Given this list of marker genes KALRN, CLIC1, HSPG2, FHOD3, VAMP8 (vesicle associated membrane protein 8), PLOD2, KDELR3, ARF4, P4HA2, MYH6, TTR, SGCE, PLOD1, TCERG1, TYRO3, ENTREP1, STARD10, MBNL2, RRBP1, PTPRM, AQP8, WARS1, AMFR, SNAI1, SURF4, LMBRD1, VEGFA, UBE2Q2, TFPI, ENPEP, PDIA3, AMOTL2, CYP26A1, PGA5, ZNF644, CCNC, SLC7A1, EFEMP2, MYL3, B4GALNT2, TST, YPEL2, ITGB1, LAMC1, EXT1, APP, MFGE8, SFMBT2, YAF2, CTSZ (NCBI Gene Id 1522), TMED2, GATA6, GLUL, NID2 (NCBI Gene Id 95183), EPAS1, COL4A2, DOCK9, CREB3L1, SPOCK1, FKBP9 (NCBI Gene Id 90212), FUT8, FLRT3, PTH1R, LRPAP1, CLU, CST3 (NCBI Gene Id 1471), GNAS, CITED2, FBXL22, SYCP3, GRINA, GHR, LAMB1, ERP44, COL4A1, GNG10, CDC42SE2 (NCBI Gene Id 56990), ANKRD50, CCND2, HS3ST1, IGFBP4, LPP, MPZL2, BACH1, F3, HOXC6, TLNRD1, ID2, FURIN, SUSD2, GANAB, SEMA6D, TCF7L2, SLC38A1, MSL3, RCOR1, ZYX, ZFHX3 (NCBI Gene Id 463), HSDL1, PXDN, SLC16A1, THBD, JUND, GNA12, CCN1, COL4A5, GNS, MDFIC, SPINK1, P4HA1, GREM2, TIMP3, DDAH1, PSAP, CDC42EP1, CD38, STRA6, NR2F2, PTPN9, P4HB, FNDC3A, RAMP2, TNFRSF10B, EPOP, PARVB, LGMN, PSPH, FDX1, KDELR2, CUL1, SRPRB, RCN1 (NCBI Gene Id 5954), INTS6L, PLAT, EPHB4, ANXA2, SERPING1, LAMA1, GGTA1, ATP1B1, DYRK2, CALU, PDE1B, HERPUD1, SEMA6A (NCBI Gene Id 57556), KIT, CASKIN2, GALNT2, MAN1A2, SPARC, PRPF38B, SRGN, CALM1, CITED1, SOX17, CDH5, NID1, CTSV, ATP6AP1, COBLL1, B2M, FBLN2, RNF24, CRYAB, SERPINH1 (NCBI Gene Id 89588), CYB561A3, NR4A1, here is a description of the gene set: Elongin A is a transcription elongation factor that increases the overall rate of mRNA chain elongation by RNA polymerase II. To investigate the function of Elongin A in vivo, the two alleles of the Elongin A gene have been disrupted by homologous recombination in murine embryonic stem (ES) cells. The Elongin A-deficient ES cells are viable, but show a slow growth phenotype because they undergo a delayed mitosis. The cDNA microarray and RNase protection assay using the wild-type and Elongin A-deficient ES cells indicate that the expression of only a small subset of genes is affected in the mutant cells. Taken together, our results suggest that Elongin A regulates transcription of a subset but not all of genes and reveal a linkage between Elongin A function and cell cycle progression. Human Gene Set: YAMAZAKI_TCEB3_TARGETS_UP Genes up-regulated in embryonic stem cells from TCEB3 knockout mice. from publication Yamazaki K, Aso T, Ohnishi Y, Ohno M, Tamura K, Shuin T, Kitajima S, Nakabeppu Y (PMID 12604609) studied in species Mus musculus